The following is a description of a gene set: studied in species Mus musculus Genes predicted to be targets of miRBase v22 microRNA mmu_miR_100_5p, mmu_miR_99a_5p in miRDB v6.0 with MirTarget v4 prediction scores > 80 (high confidence targets). from publication Chen Y, Wang X (PMID 31504780) Mouse Gene Set: MIR_100_5P_MIR_99A_5P, and this is the list of marker genes: Nox4, Zfp689, Mtor, Kbtbd8, Ptgir, Raver2, Zzef1, Ctdspl, Smarca5, Fgfr3, Ap1ar, Baz2a, Ttc39a, Fgf21, Seh1l, Hs3st3b1, Hs3st2